The following is a description of a gene set: Death in during childhood, defined here as between the ages of 2 and 10 years. species: Homo sapiens Death in childhood Human Gene Set: HP_DEATH_IN_CHILDHOOD, and this is the list of marker genes: FADD, SMN1, HMGCL, TNFRSF11A, FGA, WT1, FKRP, NDUFB8, SLC52A3, MFF, COX5A, SLC33A1, SCN1B (NCBI Gene Id 6324), CAMSAP1 (NCBI Gene Id 55490), TTC7A, NHLRC2, FGB, ATP1A2, SMARCD2, ELOVL4, PIGY, PMM2, NOP10, MADD, AP1S1, ATP5MK, RRAGC, SERPINH1, MRPL3, JPH2, ACTA1, VPS50, PTPRC, MT-TN, FGG, DPH1, EFL1, RMND1, CLCN3, ALG11, MRM2, PQBP1, UBR1, TPP2, ERCC2, NAXD, LTBP4, TSFM, LAMA3, ATG7, OGDH, C2orf69, NADK2, CD3G, LAMB2, EXOSC8 (NCBI Gene Id 11340), POT1, GNPTAB, RNASEH2C (ribonuclease H2 subunit C), SURF1, MBTPS2, NUP214, RNU4ATAC, PPCS, GAD1, ERCC1, PEX2, ARHGEF9, TMEM70, VPS33A, STT3B, ACTL6B, SLC25A22, SEC31A, PAM16, FCHO1, ADCY5, PEX5, NAXE, SUCLG1, ELAC2, OAS1, PEX1, NDUFS7, ERCC6, AARS2, KRT5, PET100, RINT1, TSEN2, CRPPA, C18orf32, FARS2, FTO, GFAP (NCBI Gene Id 2670), TSEN54, TIMMDC1, NFIX, NPC2, LAT, RARS2, ABAT, RAB27A, ACAD9, SLC17A5, MFSD2A, RBMX, NDUFV1, DLD, DKC1, KARS1, SCYL2, TK2, ZNFX1, ATP7A, SNAP29, NEB, GFM2, DTYMK, ABCB11, MTX2, HEXB, PLCB3, ATPAF2, CAD, LYRM7, RNASEH2A, PRPS1, EFEMP2, MPI